The following is a description of a gene set: Human Gene Set: GOBP_SYNAPSE_MATURATION The process that organizes a synapse so that it attains its fully functional state. Synaptic maturation plays a critical role in the establishment of effective synaptic connections in early development. species: Homo sapiens, and this is the list of marker genes: IGSF9 (NCBI Gene Id 57549), PALM, SHANK1, SNX27, DLGAP4, DAB1, ADGRB3, NEUROD2, NEURL1, CCDC39, PTEN, ARHGEF15, AGO2 (argonaute RISC catalytic component 2), DAB2IP, CX3CR1, NRN1, CLSTN1, RELN, CHRDL1, SEMA7A, FGF22, SYBU, IGSF21, DISC1, ROCK1, ANAPC2, NRXN1, SEZ6L2, CNTNAP1, LNX1, SEZ6, SEZ6L, NFATC4, NFIA, YWHAZ (tyrosine 3-monooxygenase/tryptophan 5-monooxygenase activation protein zeta), FGF7, C1QL2, CAMK2B, BCAN, CDC20, VPS35, PFN1, NEFL